The following is a description of a gene set: studied in species Homo sapiens We have identified more than genes that have upregulated expression in TLR3 activated (PMI-1,2), but have downregulated expression in TLR2 activated (PMP-1,2) macrophages, as compared to control cells (PMC-1,2) Human Gene Set: GSE36891_UNSTIM_VS_POLYIC_TLR3_STIM_PERITONEAL_MACROPHAGE_DN Genes down-regulated in peritoneal macrophages: untreated versus poly(IC). from publication de Freitas A, Banerjee S, Xie N, Cui H, Davis KI, Friggeri A, Fu M, Abraham E, Liu G (PMID 22573805), and this is the list of marker genes: L3MBTL3, BFAR, PARP12 (poly(ADP-ribose) polymerase family member 12), RAP2A, CPSF4L, TSTD2, TNFRSF11A, RNF34, INTS9, CHST1, GNB4, MS4A6A, PDE8A, MCMBP, AP1G1, HSPE1 (heat shock protein family E (Hsp10) member 1), PHLPP1, PELI1, S1PR1, ZNF217, PARP8, HCK, PRNP, SLC2A6, NFKBID, SLC28A2, RNF144B, CCL13, LRCH3, SLC7A8, HINFP, ITPK1, ETV3, TCF4, PUS10, BCO2, PSTPIP1, RBL1, PLEKHA2, ENDOD1, LYN, ARHGEF3, MINPP1, SNN, CASP1, CHMP5, USP42, CFB (NCBI Gene Id 629), EIF2S1, NAP1L2, DBR1, RSL24D1, ARID3B, LGALS3BP, STAMBPL1, PEX26, PCSK7, RASA3, GCNT2, SIK1, APOOL, CCL2, VIPAS39, AREL1, PSME1, NECAP1, RIN2, CORO2A, PDSS1, SMIM3, PLEKHG1, APOBEC3B (apolipoprotein B mRNA editing enzyme catalytic subunit 3B), DENND1B, PPIP5K2, IFI27L2, CYTH1, LARGE1, CDKN1A, ZNF800, SLC29A3, SPATA13, G3BP2, PARP11, SLC30A1, SPRY2, ARL4C, PLAAT3, CCR5, CMTR1, CASP8, MACIR, BMAL1, DBNL, SYNJ2, FABP3, MITD1, GPR65, CAB39L, TOR1AIP2, TMEM51, TAL1, CCNG2, UBE2E1, PTTG1, KHDRBS1 (KH RNA binding domain containing, signal transduction associated 1), CHMP4B, USP25, TDRD7, SELENOW, PCYT1A, ACSS2, FBXO4, PNP, SNW1, OGFR, OAS3, P2RY14, ADAR, TAOK3, PPP1R13B, FOS, IL18 (NCBI Gene Id 3606), ISG20, ST8SIA1, TRIM34, ARHGAP17, AZI2, DUSP28, GLIPR2, FAM72A, SASH1, ASCC3, TCOF1, XDH, VCPIP1, FEZ2, MARCHF5, SOCS2, CHRNA5, MORC3, ARHGAP11A, LPXN, IQSEC2, TMCC3 (NCBI Gene Id 57458), SMG7, ASS1, LLGL1, BST2, PLOD3, ZDHHC18, TLR8, NFIX, ZNF213, CGAS, PDE6C, SESN3, SEPTIN10, CRYBG1, DNAJA2, ITPRIP, PHYH, SPEN, OSM, FAM241A, PIGV, XKR8, UTP3, AKAP12, MGAT4A, NAA20, KAT2B, CD164, TSPO, PML, CWC22 (CWC22 spliceosome associated protein homolog), DOP1A, SMOX, AXL, CXCL10, AOPEP, OTUD1, FBXO9, IRF9, HHEX, CYSLTR1, UGCG, HAT1, PRMT9, MYD88, HAP1, HEATR5B, FILIP1L, CCDC86 (coiled-coil domain containing 86), XRN2 (5'-3' exoribonuclease 2), SLAMF9, NFKBIZ, PLEKHA3, ABCG1, FNBP4, NSD3